The following is a description of a gene set: studied in species Homo sapiens Human Gene Set: GOBP_DISRUPTION_OF_ANATOMICAL_STRUCTURE_IN_ANOTHER_ORGANISM The disruption of an anatomical structure of another organism, leading to damage or temporary subversion of that structure., and this is the list of marker genes: MUC7 (NCBI Gene Id 93297), LYZL6, GBP5, DEFA1B, GZMM, HAMP, CCL1, CXCL10 (NCBI Gene Id 3627), GBP7, DCD, CST11, CCL19, KRT6A (keratin 6A), CCL18, SPAG11B, DEFA6, RNASE7, CFHR2, PGLYRP4, MICB, GZMA, DEFA1, RPS19, DEFA3, MYD88, CCL20 (NCBI Gene Id 6364), CXCL9, LTF, DEFB103A, CAMP, NINJ1, SCNN1B, CSNK2A1, PRF1 (NCBI Gene Id 5551), CFHR1, CFHR5, C8B, CXCL1, GBP1, GBP3, CCL8, ELANE, MICA, SEMG1, LGALS3, CTSG, DEFA5, C5, S100A12, PGLYRP3, TAC1, CHGA, CXCL12, TOR2A, ARG1, GZMH, CXCL11, ROMO1, CCL13, DEFA4, XCL1, H2BC11, CCL28, POMC, F2, PGLYRP1, CSNK2B, KNG1, NKG7, DAO, HTN3, C8A, DEFB130A, HRG, C6, DEFB118, C9, RPL30, PF4, MBL2, CCL11, NCF1, C8G, CXCL14, LCE3C, AZU1, LCE3B, DEFB103B, CXCL8 (C-X-C motif chemokine ligand 8), DEFB136, CCL21, CXCL3 (NCBI Gene Id 2921, C-X-C motif chemokine ligand 3), HMGN2, F2RL1, CXCL2, GNLY (granulysin), CXCL13, C7, GBP2, PCYOX1L, LYZ, GAPDH, HTN1, TREM1, CCL17, GSDMB, USP7, DEFB4A, H2BC12, CCL25, TUSC2, DEFB128, PLA2G2A, PPBP, NLRP6, NTS, APOL1, GZMB (granzyme B), CCL22, NPPB, CCL27, LCE3A, DEFB132 (defensin beta 132), PI4KA, CXCL6